Given this list of marker genes SPIRE1, ZFYVE27, ANO6 (NCBI Gene Id 196527), NPM2, SMCR8, DOC2B, EPHB2, OBSL1, STK25, PLA2G3, RHOQ, ANKRD1, MAPK1, P2RX7, APOA2, MAPK8, RHOC, HFE, HNRNPA1, STK11, LRRC4B, ARRB2, WNK1, EDN1, CCN2, KIRREL1, MYC, STYXL1, AHNAK, TTBK2, RGS2, DDX56, MSTO1, YME1L1, SAXO1, NIN, METRN, CDK2, ENC1, PRKCQ, CORO1C, GRIP1, TNN, CROCC, MIR27B, SLITRK6, ATP1B2, RUNX1, FBXW8, DRD3, MARCHF5 (NCBI Gene Id 54708), WASF3, EGF, ROCK1, TRABD2B (TraB domain containing 2B), COLGALT1, PLCB1, SMAD4, SYNPO2L, PIK3CA, WRAP73, CLASP1, PLCG2, EPS8L3, LMAN1, EHD1, MMP1, NAF1, AP2B1, ISG15, HTT, HRAS (NCBI Gene Id 338029), SIRPB1, INSR, STMP1, IL6, NF2, MAPK15, PLXNC1, RET, MICU1, FHOD1, EPGN, ITGA2, ABCB7, SCIN, CLIP3, ATF1, ZDHHC5, MERTK, EREG, AMIGO1, WASHC5, APLNR, EPHA2, MIR1-1, TTBK1, MIR21, ALKAL1, SMURF1, SERPINE1, TFR2, CCR7, PTK7, TRABD2A, VPS35, GBP2, DOCK2, MAP2K1, OSBP, LYN, IER3IP1, NAV3 (NCBI Gene Id 89795), C2CD5, FUT9, MACF1, HIP1R, ENTR1, SYNJ1, CFLAR, SLIT2, PAN2, THY1, NLGN1, RUFY3, PRKN, YY1, PTPN22, STAT3, EIF5A, SKIL, CD28, CAMK1D, CNTF, CCT8, ABCA3, SH3GLB1, SEMA4D, FLRT3, IRX3, RAD21, NTRK2, EPHB1, VTN, TENM3, FERMT2, MAP3K4, COBL, RAD51AP1, PDPN, S100A10, SYNDIG1, HCK, MEIOSIN, MDK, MARK4, LMAN2, TF, NPR2, SDC1, LTK, FYCO1, NEFL, ATOH7, BTK, DUSP3, CCL21, NPHP4, AMIGO2, LRP5, NUMBL, TPR, EPO, CCL11, GRB2, FNIP2, RACK1, AGRN, IL1RAPL1, GPC3, MTSS1, SKAP1 (NCBI Gene Id 8631), PINK1, BRAF (NCBI Gene Id 673), FES, LPAR3, CEP295, MAVS, PPP3CA, MTOR, DVL1, TNXB, VCP, RB1, SYT5, ALK, BID, MYO3B, CTNNB1, PCSK9, RAB31, TRPC5, TOR1A, CALR, TPBG, BMPR1A, CARMIL2, MSX2, TMEM106B, PRAP1, IL1A, S100A9, ACTR2, PDE4DIP, RUVBL2, ITGB1BP1, ARHGEF7, IL15RA, MARK2, CHODL, STAU2, PTGES3, PRKACA, TFRC, ACTR5 (NCBI Gene Id 93972), NES, NRG1, MYOC, SGIP1, BAIAP2, PTPRC, LGALS3, INO80D, DHX33, TGFA (transforming growth factor alpha), GPC2, AHI1, SELE, CCP110, BTC, BBS4, SWAP70, TIAM1, MAP2K2, AMBRA1, PPP1CA, EVL, ZMYND8, TUB, PNKP, NSMCE2, PIP4K2B, GPX1, NFRKB, FZD1, NCKIPSD, EHD2, ROBO2, MYLK3, DAZL, HNRNPA2B1, SLITRK1, VPS4B, FMR1, MET (MET proto-oncogene, receptor tyrosine kinase), DCTN1, HRK, ANKFY1, STAP1, EFNA5, FER, RAP1B (NCBI Gene Id 5908), TPPP3, ITSN1, DDX11, TGFB3, CLSTN3, NEDD9, NTRK3, PARK7, SFRP4, CNTNAP2, ERCC1, ATP10A, NDRG4, TGFB2, ADD1, ARHGEF5, KDR, PMAIP1, CBLN2, CDC20, CDC42EP5, RPS3, CENPJ, DVL3, ABCA13, PROM2, SPACA3, ATP5IF1 (ATP synthase inhibitory factor subunit 1), PRRT2, ANXA2P2, RND2, INO80B, GREM1, RAB8B, ACTR8, RELN, NCAPG, CHCHD10, RAPGEF3, PRDM9, TSC1 (NCBI Gene Id 7248), TERF1, WASF1, ATR, PTPN23, CNTN1, WNT4, AJUBA, SIRPA, VLDLR, DBN1, USP8, IFNG, FUZ, IGF2, PYCARD, CCT7, PIEZO1, NOX1, FAM162A, NPHP1, CARMIL1, CDC42EP1, FCN1, ANXA1, ARHGEF10, CDH4, PLD6, SYT2, THBS2, DDHD1 (NCBI Gene Id 80821), PLEK2, ABCA1, SF3A2, SLF1, DLG5, SDC4, TMED9, SMAD1, XRCC4, BAX, APOA1, COLEC10, CD300LF, PRKCA, TRAK1, SDCBP, NTN1, RTEL1, BCR, NCKAP1, STIL, PLCE1, ACD, IL17A, CYFIP1, RETREG3, CCL8, EIF4G1 (NCBI Gene Id 1981), HSF1, SIRT2, BUB1 (NCBI Gene Id 699), WNT10B, TULP1, CCL26, ISLR2, SIVA1, DISC1 (NCBI Gene Id 80138), CDH5, CNOT2 (CCR4-NOT transcription complex subunit 2), NTF3, CALCOCO2, C4A, RAB21, ATM, ABI2, USP50, ADGRB1, SEMA5A, FERMT1, CCT3, DLG1, EPB41L5, PRKCI, IQSEC1, HSPA1A, SLX4, CBL, SFPQ, PAFAH1B1, BAD, DSTN (NCBI Gene Id 11034), APBB1, MAPK14, HOXA13 (NCBI Gene Id 3209), ANXA2, TOM1, PXN, CSF3, PTPRJ, APELA, MNS1, ABCB4, UNC13B, WARS1, UVRAG, SYT11, DDR1, ABL2, RIT2, ZDHHC1, NPHS1, CDKN1B, HAMP, TNF, BMP5, SCGB3A1, PROX1, AMOT, LRRC24 (NCBI Gene Id 441381), TLR4, SYK, BIK, SEMA7A, EPHA4, LIG4, PLXNA3, ANKRD27, FLRT2, CCDC15, CXCL12 (NCBI Gene Id 6387), SPAST, ZNRF1, PLPPR5, VSTM5, GPER1, DSG3, ELAPOR1, PFDN2, SPAG5, BICD1, SMPD3, FGF8, ADD3, SNX4 (sorting nexin 4), NCAPD2, BRK1, ATAT1, MOAP1, CAPRIN1, INS, SETX, MIR17, LMOD2 (leiomodin 2), IRGM, NCAPH, CUX1, ZNRF2, CDC16, POLDIP2, COLEC11, NEDD4L, ULK1, P3H1, ITGA6, PIP4K2C, CFL2, RAPGEF1, OCLN, FCGR2C, FZD4, KAT2B, ICE1, TPPP2, PAK1, IGF1, DKC1, SLC18A3, ARRB1, SCARB2, GPRASP3, TACR1, CFL1, TAPT1, CLDN5, OOEP, CRB3, SIRT6, TOGARAM1, ADNP, SLX1A, MEGF8, C2, ZDHHC2, CXCL13, ATMIN, CD36, CFP, CLSTN1, DYNC1H1, LINGO2 (leucine rich repeat and Ig domain containing 2), PSMC5, DDR2, LPAR1, PLXNB3, TENM1, APPL1, SHOX2, IL15, ADGRB2, RPH3AL (NCBI Gene Id 9501), APOA5, NCAPH2, GAS6, MACROH2A1, PFN1, ACTL6A, SLITRK2, FEN1, SSBP1, PTN, CDC42EP4, KDM1A, NEGR1, LYAR, MAP2K7, AP2M1, CDKL3, STX18, SS18L1, STRA8, WASHC2C, PLXNB2, TBC1D5, NCK2, DCSTAMP, C15orf62, FCER1G, PSRC1, CD63 (NCBI Gene Id 967), SYT1, BNIP3, TINF2, WASHC1, RPH3A, DCN, NLGN3 (NCBI Gene Id 54413), LRP8, RAB27A, TRIM58, MAPRE2, CSF2, APPL2, PHIP, TNKS, VIL1, CRABP2, FLNA, ANAPC7, STUB1, MIEF2, GBP5, DZIP1 (NCBI Gene Id 22873), EIF5A2, MIB1, P2RY12, GNL3L (G protein nucleolar 3 like), CLN3, ENDOG, KATNBL1, AZU1, CKAP5, KAT2A, TREM2, DAB2IP, PTK2B, FSCN1, ANGPT1, TBC1D24, PLA2G5, LRRK2, ANKRD53, ADGRB3, SOX9, MIR200C, DAB2, TMEM30A, CX3CL1, ALKAL2, POC1B, SFRP1, BAG4, PLEKHM1 (NCBI Gene Id 9842), NRXN1, DDHD2, ATP8A1, ARAP1, ADAM9, MIEF1, L1CAM, TCP1, ARHGAP35 (NCBI Gene Id 79266), MAGEL2, MMP9, HSP90AA1, SHOC2, WNT5A, DDX3X, CLASP2, MSX1, ARMCX5-GPRASP2 (ARMCX5-GPRASP2 readthrough, NCBI Gene Id 100528062), TWF1, PPP1R35, KCNK6, SLITRK5, MSTN, FN1, PML, PICK1, TSG101, SYNPO, LRRTM3, ITPKA, ZEB2, DHX36, MAGI2 (NCBI Gene Id 9863), FCGR2B, SMC2, OCSTAMP, CUL7, BAIAP2L1, MAD2L1BP, SMC4, EPS8L1, MMP3, SASS6, BAK1, MRE11, SEPTIN9, CTTN, CRACD, HRG, SLITRK3, MELTF, EPHA3, NUP62, PLXNB1, KCTD17, SPHK1, ABL1, CDH17, ESPL1, IST1, INO80E, CCT5, ARHGEF15, SKA3, MIR431, APC, RICTOR, EEF2K, CLSTN2, LCN2, MIEN1, ANK1, SCN1B, PIP4K2A, SLC30A1, TRIM32, SURF4, TNFSF14, RUVBL1, CD53, INO80C, ATG2A (NCBI Gene Id 23130), SRPX2, PLK4, MAPKAPK5, MAD1L1, SYNPO2, STMN2, INO80, LMOD1, RGCC, RAB3GAP2, CORO1B, CAPRIN2, PSEN1, ACVRL1, POU4F2, MAPRE1, SYT4, TEK, CLEC7A, C4B, FCGR1BP, AKIRIN1, NVL, MIR221, GRID2, RIPOR2, ANLN, BECN1, SYT9, MYO18A, APP, MIR183, SMC5, F2RL1, MCRS1, CNOT6L, AMIGO3, KAT5, LATS1, DNM1L, SERPINF1, LRSAM1, DOCK11, LRRN1, MAP6, EPHB3, MLLT11, NLGN2, MECP2, TPM1 (tropomyosin 1), NTRK1, WNT3A, PPT1, SORBS3, CDK1, HAS3, CRBN, GSN, BMF, CALY, DEF8, CAND1, SMPD1, LATS2 (large tumor suppressor kinase 2), ACTN2, MIR133B, EPS8L2, LRRTM1, TNKS2, TAC1, LDLRAP1, BMP2, GSK3A, CNOT1 (CCR4-NOT transcription complex subunit 1), CBLN1, NUMA1, PAN3, NEK2, NEURL1, WASL, IL2RG, DLG4, TRPV2, IGF1R, CAV1 (NCBI Gene Id 857), UBE2B, BRCC3, FBXO4, CUX2, ARSB, FPR2, PRKD1, SNCA, LIMCH1, PLAUR, SYT13, MYD88, FBXO38, RAC1, LRRN3, EP300, RAP1GAP, FEZ1, NBN, UBE2C, IL4, TPPP, KIDINS220, ATG5, MED25, LRTM2, RAPGEF2 (NCBI Gene Id 9693), CUL3 (cullin 3), ROBO1, MPP7, FGFR1, RP1, BAIAP2L2, DPYSL3, ARHGEF10L, SRF, SYT3, PRKCE, MIR205, RALA, DLL1, BMP10, HDAC6, GIT1, FCGR2A, ATRX (ATRX chromatin remodeler), B2M, TOX, LRP1, BMP7, SSH1, FIS1, MFF, HAP1, PACSIN1, FRMD7, ERC2, ARPC2, DMD, ASIC2, CCL24, TRIM65, GDF15, NDEL1, BBC3, PARN, MSN, CAPN2, GH1, EFEMP2, GHRL, AR (androgen receptor), GPIHBP1, BMPR2, LIMS1, TFPT, NCKAP1L, IL5, KLF4, DMRT1, SLC11A1, LRRC7, ATAD1, ENPP2, RALBP1, NEUROD2, MUL1, TRPV4, GNL3, CREB1, PDCD6IP, LRRTM2, ITGA3, HYAL1, SLF2, SHCBP1L (NCBI Gene Id 81626), WDR1, PSMC6, ZNF804A, RAB3GAP1, SUMO1, ZDHHC15, C3, TP53, NGF, PDGFRB, IL1B, ARL2, GPM6A, SYT7, CDC42EP3, TERF2IP, PFN3, SLAIN1, CCL19, ADCY10, LCP1, CAMK2B (NCBI Gene Id 816), SH2B1, NFE2L2, IFT20, CCT2, BCL11A, DGKD, DTNBP1, IL1RAP, AVIL, SLITRK4, FLRT1, SEMA4A, LINGO4, PGAM5, FYN, CLIP1, NFATC2 (NCBI Gene Id 4773), MAPK9, RHOA, CDC42EP2, SIRPG, TUBB2B, TBX5, ZMYND10, MLST8, TGFBR1, FNIP1, ASAP1, CEP120, PPM1F, SCARF1, SOD1, GOLGA4, WRAP53, NEK7, TENM2, GDI1, PALM, DVL2, LNPK, PTK6, POT1, NABP2, CDC42, PLEK, ANAPC2, PPP2R5B, NCK1, EPS8, FCHSD2, SEPTIN7, CCDC88A, DRG1, SNX7, GPSM2, RAD50, NCAPG2 (non-SMC condensin II complex subunit G2), FRMPD4, PLXND1, ADCK1, PTPRD, ATP8A2, SKA1, MYO3A, SPIDR, EDN3, CLU, NR1H2, ACTR3, TWF2, TLR6, UBAP2L (ubiquitin associated protein 2 like), CAMK1, IL4R, WDR45, DLGAP5, CLDN1, DSCAM, CXCL9, BOK, SNX3, ALOX15, SERPINI1, WNT1, IL2RB, GCM1, SNX18, DOC2A, SRC, UCHL5, EIF5AL1, APOC2, PIWIL2, CCT6A (NCBI Gene Id 908), ABCC8, RAP1A, PUM2, ST8SIA2, FAM98A, CBFA2T2, HIP1, MTLN, CDK5RAP2, KHDC3L, NRDC, PKIB, CBLL1, MAPT, TIRAP, TYROBP, RGMA, FASLG (NCBI Gene Id 356), IQSEC2, WNT7A, VASP, CEP135, GATA2, TGFB1, BIN1, SERPINF2, TIAM2, SNX9, FCN3, DRD2, PPP2CA, APOE, ANAPC5, GPR65, SHTN1, CASP7, KIT, RALB, EMILIN1, CAPG, CD47, WASF2, TERF2, TRIM27, ANAPC11, PLK5, TNFSF10, WHAMM, HNRNPD, TAL1, PPM1E, CCT4 (chaperonin containing TCP1 subunit 4), AGT, AUTS2, RYK, GRN, RAB11FIP3, CDC23, SLAIN2, AP2A1, TESK1, PARP6 (NCBI Gene Id 56966), CD151, PIK3R1, ZNF205, GSK3B, CDKL5, MAP1B, EZH2, JMJD4, NDNF, MCU, MIR20A, FNBP1L, H1-1, SFTPD, LRP4, MAP3K13, PTX3, MYOD1, CNOT6, FCGR1A, AURKA, APLN, PFN2, FLOT1, ACE2, NPTN, NRP1, SLX1B, SNX30, WNT3, ABCA7, PPP1R10, FIG4, VEGFA, ROCK2, SMAD3, EPHA1, PPP3CB, RREB1, HOPX (HOP homeobox), ADRB2, PDXP, COL16A1, FCN2, AXL (AXL receptor tyrosine kinase), HSPA1B, ARF6, CYBA, BDNF, MIR222, CD14, MCOLN1, AURKB, SYT8, VPS28, CCL2, ROBO3, NCAPD3, CDK5R1, MAPK3, PPP3CC, GDF2, KATNB1, PDGFB, MBL2, IFT88 (intraflagellar transport 88), ZDHHC6, CLRN1, WIPI1, BCL2L11, MAP4K4, RAC2, LIMK1, TRIM67, CAV3, FCHSD1, OXT, SHANK3, SLN, AKAP9, TNFRSF12A, RASIP1, AHSG, NUSAP1, here is a description of the gene set: Human Gene Set: GOBP_POSITIVE_REGULATION_OF_CELLULAR_COMPONENT_ORGANIZATION species: Homo sapiens Any process that activates or increases the frequency, rate or extent of a process involved in the formation, arrangement of constituent parts, or disassembly of cell structures, including the plasma membrane and any external encapsulating structures such as the cell wall and cell envelope.